Given this list of marker genes Calcrl, Npn2, Fhl1, Irx3, Cxxc5, Rbpms, Nras, Ankrd1, Polr2m, here is a description of the gene set: Genes down-regulated in MEF cells (embryonic fibroblasts) isolated from HRAS and NRAS double knockout mice. We characterized differential gene expression profiles of fibroblast cell lines harboring single or double-homozygous null mutations in H-ras and N-ras. Whereas the expression level of the individual H-, N- and K-ras genes appeared unaffected by the presence or absence of the other ras loci, significant differences were observed between the expression profiles of cells missing N-ras and/or H-ras. Absence of N-ras produced much stronger effects than absence of H-ras over the profile of the cellular transcriptome. N-ras(-/-) and H-ras(-/-) fibroblasts displayed rather antagonistic expression profiles and the transcriptome of H-ras(-/-) cells was significantly closer to that of wild-type fibroblasts than to that of N-ras(-/-) cells. Classifying all differentially expressed genes into functional categories suggested specific roles for H-Ras and N-Ras. It was particularly striking in N-ras(-/-) cells the upregulation of a remarkable number of immunity-related genes, as well as of several loci involved in apoptosis. Reverse-phase protein array assays demonstrated in the same N-ras(-/-) cells the overexpression and nuclear migration of tyrosine phosphorylated signal transducer and activator of transcription 1 (Stat1) which was concomitant with transcriptional activation mediated by interferon-stimulated response elements. Significantly enhanced numbers of apoptotic cells were also detected in cultures of N-ras(-/-) cells. Our data support the notion that different Ras isoforms play functionally distinct cellular roles and indicate that N-Ras is significantly involved in immune modulation/host defense and apoptotic responses. studied in species Mus musculus Mouse Gene Set: CASTELLANO_HRAS_AND_NRAS_TARGETS_DN from publication Castellano E, De Las Rivas J, Guerrero C, Santos E (PMID 16909116)